The following is a description of a gene set: Genes up-regulated in H1975 cells (non-small cell lung cancer, NSCLC) resistant to gefitinib after treatment with EGFR inhibitor CL-387785 for 6h. species: Homo sapiens Activating mutations in the epidermal growth factor receptor (EGFR) tyrosine kinase domain determine responsiveness to EGFR tyrosine kinase inhibitors in patients with advanced non-small cell lung cancer (NSCLC). The modulation of transcriptional pathways by mutant EGFR signaling is not fully understood. Previously, we and others identified a single base pair change leading to a threonine to methionine (T790M) amino acid alteration in the ATP-binding pocket of the EGFR as a common mechanism of acquired resistance. The gefitinib-resistant, T790M-mutant H1975 NSCLC cell line undergoes prominent growth arrest and apoptosis when treated with the irreversible EGFR inhibitor, CL-387,785. We did a transcriptional profiling study of mutant EGFR target genes that are differentially expressed in the resistant gefitinib-treated and the sensitive CL387,785-treated H1975 cells to identify the pivotal transcriptional changes in NSCLC with EGFR-activating mutations. We identified a small subset of early gene changes, including significant reduction of cyclin D1 as a result of EGFR inhibition by CL-387,785 but not by gefitinib. The reduction in cyclin D1 transcription was associated with subsequent suppression of E2F-responsive genes, consistent with proliferation arrest. Furthermore, cyclin D1 expression was higher in EGFR-mutant lung cancer cells compared with cells with wild-type EGFR. EGFR-mutant cells were routinely sensitive to the cyclin-dependent kinase inhibitor flavopiridol, confirming the functional relevance of the cyclin D axis. These studies suggest that cyclin D1 may contribute to the emergence of EGFR-driven tumorigenesis and can be an alternative target of therapy. from publication Kobayashi S, Shimamura T, Monti S, Steidl U, Hetherington CJ, Lowell AM, Golub T, Meyerson M, Tenen DG, Shapiro GI, Halmos B (PMID 17145885) Human Gene Set: KOBAYASHI_EGFR_SIGNALING_6HR_UP, and this is the list of marker genes: AQP3, KLHL24, CCNG2, CEP68, PELI1, TMT1A, PDCD4